The following is a description of a gene set: species: Mus musculus Any process that stops, prevents or reduces the frequency, rate or extent of vascular associated smooth muscle cell migration. Mouse Gene Set: GOBP_NEGATIVE_REGULATION_OF_VASCULAR_ASSOCIATED_SMOOTH_MUSCLE_CELL_MIGRATION, and this is the list of marker genes: Prkg1, Pdgfb, Myh9, Tafa5, Myocd (myocardin), Nfe2l2, Drd4, Rhoa, Ptpn1, Nf1, Mef2c, Adipoq, Gna12, Gna13, Tpm1